The following is a description of a gene set: studied in species Homo sapiens Human Gene Set: MODULE_493 Genes in the cancer module 493., and this is the list of marker genes: L3MBTL1, TIMP3, EPHB1, LCMT1, COMMD7, SMURF2, PPM1H, NSUN2, SRCAP, PDLIM7, DENND2B, SMIM29 (NCBI Gene Id 9979), ARNT2, AFAP1, EPHA4, LTBP1, ZBED5, TRAPPC2, CHD3, SSBP2, ZMIZ1, XAGE1B, DCBLD2, SOCS5, LAMB1, CRLF3, PFDN4 (prefoldin subunit 4), OFD1, ZNF189, JADE2, ATRX, MYO5C, TCF4, TPM1, SLC25A14, ST6GALNAC2, CENPT, TOB2, LPCAT2, CLIP2, EFNA4, DRAM1, SEPTIN8, LARP6, LAMA4, CKMT2, MYLIP, NDE1, CHTOP, CNNM4, MTR, ZXDC, TPTE2, CD58, DNA2, TMSB15A, UBE2E3, ZNF292, STARD9, GJA1, MITF, ZP3, OTULINL, KDM1A, PUDP, SF3B6, ABCC5, TRIP10, CTDSPL